Given this list of marker genes SGTA, USP14, UBXN1, AQP11, SVIP, USP25, UBXN2A, here is a description of the gene set: Human Gene Set: GOBP_NEGATIVE_REGULATION_OF_ERAD_PATHWAY species: Homo sapiens Any process that stops, prevents or reduces the frequency, rate or extent of ERAD pathway.